Given this list of marker genes STAT1, PDGFRB, GNAI1, NGF, RHOA, ARHGAP35 (NCBI Gene Id 79266), GAB2, PTPN11, PRKACA, SOS1, BDNF, JAK2, IL6R, KDR, EGFR, JAK1, MAP2K1, GNAI3, LCK, IL2RB (interleukin 2 receptor subunit beta), LMO4, IL2RA (interleukin 2 receptor subunit alpha), HRAS, KRAS, NTRK3, EGF, SHC1, GRB2, IRS1, NTRK2, IFNG, NTRK1, SDC2, PIK3CA, NRAS, IL2RG, GAB1, ANGPT1, IL6, PIK3R1, FRS3, NOS3, JAK3, TEK, AFDN, IFNGR1, FRS2, MAP2K2, IGF1R, PAG1, IL6ST, PDGFB, RAF1, NTF3, NTF4, IL2, VEGFA, here is a description of the gene set: species: Homo sapiens Human Gene Set: PID_SHP2_PATHWAY SHP2 signaling from publication Schaefer CF, Anthony K, Krupa S, Buchoff J, Day M, Hannay T, Buetow KH (PMID 18832364)